The following is a description of a gene set: The term collodion baby applies to newborns who appear to have an extra layer of skin (known as a collodion membrane) that has a collodion-like quality. It is a descriptive term, not a specific diagnosis or disorder (as such, it is a syndrome). Affected babies are born in a collodion membrane, a shiny waxy outer layer to the skin. This is shed 10-14 days after birth, revealing the main symptom of the disease, extensive scaling of the skin caused by hyperkeratosis. With increasing age, the scaling tends to be concentrated around joints in areas such as the groin, the armpits, the inside of the elbow and the neck. The scales often tile the skin and may resemble fish scales. Congenital nonbullous ichthyosiform erythroderma Human Gene Set: HP_CONGENITAL_NONBULLOUS_ICHTHYOSIFORM_ERYTHRODERMA studied in species Homo sapiens, and this is the list of marker genes: EBP, PNPLA1, CYP4F22, SULT2B1, SPINK5, GBA1 (NCBI Gene Id 82008), KDSR, GTF2H5, ABCA12, KRT10, ALOXE3, DBR1, TGM1, ASPRV1, TARS1, ELOVL4, POMP, ABHD5, ERCC3 (NCBI Gene Id 2071), LORICRIN (loricrin cornified envelope precursor protein), ALOX12B, ERCC2, NIPAL4, CERS3